Given this list of marker genes CXCL10, RPL32, ESYT2, SIL1, ERCC3, MAP3K2, FUZ, HLA-DPA1, HSPA1B, DNAAF8, SNX2, PSEN1, RPS18, DSG2, CCT6A, FLVCR1, DHX34, RPS5, CCNB1, PTHLH, SPTLC2, PNLIPRP1, PCTP, CRBN, ATG16L1, IFI35, CISH, AKAP5, AP1S1, TMEM143, MAD2L2, MCTS1 (NCBI Gene Id 28985), PFKFB3, SDHC, YPEL3, TFAP2B, OSGIN2, TIMP1, SPOCK2, HS6ST1, SP110, SRPRB, SYNGR1, PCCB, MIEN1, BET1L, DUSP4, COL4A5, KRT19, SERPINA3, RPL13, FGF13, LIMK2, ATE1, TRIM33, DLX5, KIF13A, SYT1, THEMIS2, LGALS8, LHX3, AAGAB, DPP6, PLCL1, CCNG1 (cyclin G1), S100A12, LBP, FRMD4A, ZNF587, AK3 (adenylate kinase 3), NBPF3 (NCBI Gene Id 84224), GEMIN7, BHLHE41, MYO5B, ZNF292, RDX, BMP6, PLPP3, OSBPL2, NUP210, CARD16, NUMA1, GTPBP3, CYTH1, PMS2P1, HOXD8, MAP4K2 (NCBI Gene Id 5871), MBD5, NOL7 (NCBI Gene Id 51406), DDX11, BOD1L1, SKIC2, LEP, DHRS3, CEBPD (CCAAT enhancer binding protein delta), DCAF10, TRIP4, CLSTN3, DNAJC9, DMD, ARPC5, LZTR1, ZEB1, GCLM, NFATC4, PPP1R11, GCHFR, DDX17, FERMT2, CCNG2, ACSL3, GAS2, here is a description of the gene set: Genes in the cancer module 192. Human Gene Set: MODULE_192 species: Homo sapiens